Given this list of marker genes Arf5, Blvrb, Psmb6, Pim1, Tpt1, Rnh1, Use1, S100a9, Ranbp1, Thoc7, Ifitm1, Cd9, Mrpl51, Rps15, Prdx2, Rhd, Lyl1, Scand1, Rpl35, Dnajc8, Ltb4r1, Hmbs, Abcg2, Ube2s (ubiquitin-conjugating enzyme E2S), Manf, Ndufa11, Ifitm2, Nherf1, Eif5a, Eif3i, Rps24, Rbm3, Dbi, Rps10, Uba52, Cst3, Ndufb8, Ppp1r35, Cope, Clec4a2, Cox5a, Psmd13, Supt4a, Psmd4, Tle5 (TLE family member 5, transcriptional modulator), Clic4, Ech1, Psmb8, Rsrp1, Twf2, Ptma, Emp3 (epithelial membrane protein 3), Rpl18a, Tmem160, Serpinb1a (serine (or cysteine) peptidase inhibitor, clade B, member 1a), Calm1, Hint1, Rpl8, Jchain, Prkab1, Lamtor1, Rpl3, Cdk2ap2, Lrg1, Ddx39a, Cers2, E2f2 (E2F transcription factor 2), Rps19, Gpx4 (glutathione peroxidase 4), Rplp2, Rpl41, Ybx1, Rplp1, Rps11, Atp5pd, Rps4x, Rpl13, Fpr2, Znhit1, Jund, Fau, Map2k2, Rps2, Cotl1, Pgls, Car2, Elob, Shisa5, Arpp19, Cct7, Atp5f1d, Rps6, Atf4, Mrpl20, Anp32e, Calr, Arpc3, Npc2, Limd2, Rbm8a, Cox4i1, Csnk2b, Fkbp2, Pdap1, Tmsb4x, Pfdn6, Psmb4, Abhd17a, Necap2, Dctn3, S1pr4, Ltb, Ethe1, Cd52 (CD52 antigen), Ndufb7, Mrgpra2b, Rpl29, Gnb1, Tsc22d4, Pkm, Phf5a, Ran, Rpl6 (NCBI Gene Id 19988), Phb2, Erh, Smdt1, Aurkaip1, Psmb3, Swi5, Bsg, Rps9, Prelid1, H2ac6, Rplp0, Mthfd2, Ndufb9, Eif4e2, Spi1, Urod, Rpl13a, Rpsa, Mpst, Emc10, Bud31, Lamtor4, H2-Ab1, Hp, Psmb1, Elovl1, Comt, Prr13, Tomm6, Alad, Rpl10a, Chchd2, Ap2s1, Cyba, Eef1d, Tmsb10, Rpl7a, Rbm42, Psma7, Rps3a1, Cyc1, Pfn1, Rps3, Sin3b, Fth1, S100a6, Anp32b, Rpl32 (NCBI Gene Id 19951), Rpl28, Raly, Capg, Rps18 (NCBI Gene Id 20084), Clic1, Myl6, Chchd10, Uqcrh, Lmo4, Pdzk1ip1, Cfl1, Lcn2, Hcls1, Dok3, Atp5if1, Chmp2a, Imp4, Eif3k, Rpl14, Rps5, Alox5ap, Pglyrp1, Ptp4a3, Fkbp8, Gypa, Cdkn2d (NCBI Gene Id 12581), Uqcr10, H3f3b, Rpl19, Ube2l3, Bcl2l1, Ptpn1, Arhgdia, Tspo, Eif3f, Vcf1, Snrpc, Cdc37, Pold4, Rpl10, Lgals3, Sf3b2, Rexo2, Cldn13, Abhd5, Reep5, Wfdc17, Lamtor2, Arpc1b, Cox5b, Syf2 (NCBI Gene Id 68592), Rpl11, Tpm3, Ube2k, Ngp, Tmed9, H2-D1, Lsm4, Tbcb, Rpl15, Pkig, Rab24, Idh3g, Spag7, H2az1, Rpl23a, Rps7, here is a description of the gene set: species: Mus musculus Mouse Gene Set: TABULA_MURIS_SENIS_MARROW_IMMATURE_B_CELL_AGEING from publication Tabula Muris Consortium (PMID 32669714)